The following is a description of a gene set: Genes positively differentially expressed in cell type: CD4+ T cell upon treatment with cytokine: IFN-κ in mouse lymph nodes in vivo. from publication Cui A, Huang T, Li S, Ma A, Pérez JL, Sander C, Keskin DB, Wu CJ, Fraenkel E, Hacohen N (PMID 38057668) Mouse Gene Set: CUI_T_CELL_CD4_IFNK_RESPONSE_UP studied in species Mus musculus Cytokines mediate cell-cell communication in the immune system and represent important therapeutic targets. A myriad of studies have highlighted their central role in immune function, yet we lack a global view of the cellular responses of each immune cell type to each cytokine. To address this gap, the authors created the Immune Dictionary, a compendium of single-cell transcriptomic profiles of more than 17 immune cell types in response to each of 86 cytokines (>1,400 cytokine-cell type combinations) in mouse lymph nodes in vivo. A cytokine-centric view of the dictionary revealed that most cytokines induce highly cell-type-specific responses. For example, the inflammatory cytokine interleukin-1β induces distinct gene programmes in almost every cell type. A cell-type-centric view of the dictionary identified more than 66 cytokine-driven cellular polarization states across immune cell types, including previously uncharacterized states such as an interleukin-18-induced polyfunctional natural killer cell state., and this is the list of marker genes: Ifi35, Trim12c, Samd9l, Trim56 (tripartite motif-containing 56), Ddx60, Chmp4b, Bst2, Ifi206, Trim34a, Xaf1, Ifit1, H2-T22, Parp14, Trim12a, Gbp9, Mndal, Ifi27l2a, Slfn5, Slfn8 (schlafen 8), Trim30a, Gbp4, Psmb8, Dhx58, Ifi203, Ms4a4b, Ifi213, Ifit1bl1, Oasl2, Daxx, Trim30d, Ifit3b, Ifi47, Helz2, Rsad2, Zbp1 (Z-DNA binding protein 1), Isg20, Irf9, Dtx3l, Slfn1, Psme2, Pml, Herc6, H2-T23, Ifi208, Shisa5, Ifit3, Oas3, Usp18, Lgals3bp, Rnf213, Iigp1, Psmb10, Ccnd2, Irgm1, Ly6e, Ms4a6b, Ly6a, Stat1, 9930111J21Rik2, Parp9, Ifih1, Eif2ak2, Gbp7, Irf7, Mitd1, Ifi214, Tapbp, Igtp, Ifi209, Ddx24, Epsti1, Phf11b, Sp100, Isg15, Rigi, Slfn2 (NCBI Gene Id 20556), Psme1, Rtp4, Phf11c